Given this list of marker genes SLC39A4, COL7A1, MMP1, SLC30A2, IARS1, here is a description of the gene set: studied in species Homo sapiens Human Gene Set: HP_DECREASED_SERUM_ZINC A reduced concentration of zinc in the blood. Decreased serum zinc